The following is a description of a gene set: studied in species Mus musculus Genes negatively differentially expressed in cell type: cDC1 (conventional dendritic cell type 1) upon treatment with cytokine: IL-15 in mouse lymph nodes in vivo. Mouse Gene Set: CUI_CDC1_IL15_RESPONSE_DN from publication Cui A, Huang T, Li S, Ma A, Pérez JL, Sander C, Keskin DB, Wu CJ, Fraenkel E, Hacohen N (PMID 38057668) Cytokines mediate cell-cell communication in the immune system and represent important therapeutic targets. A myriad of studies have highlighted their central role in immune function, yet we lack a global view of the cellular responses of each immune cell type to each cytokine. To address this gap, the authors created the Immune Dictionary, a compendium of single-cell transcriptomic profiles of more than 17 immune cell types in response to each of 86 cytokines (>1,400 cytokine-cell type combinations) in mouse lymph nodes in vivo. A cytokine-centric view of the dictionary revealed that most cytokines induce highly cell-type-specific responses. For example, the inflammatory cytokine interleukin-1β induces distinct gene programmes in almost every cell type. A cell-type-centric view of the dictionary identified more than 66 cytokine-driven cellular polarization states across immune cell types, including previously uncharacterized states such as an interleukin-18-induced polyfunctional natural killer cell state., and this is the list of marker genes: Igbp1, Tubb2a, Fbl, Ighm, Zfp36l2, Pglyrp1, Polr1d, Ckb, BC028528, Rab7b, Celf2, Sec11c, Rsl1d1, Pianp, Ap1b1, H2-Ob, Lat2, Pten, Arhgap45, Hnrnpa1 (NCBI Gene Id 52621), Pdcd2l, Rp9, Rtcb, Eif2b2 (NCBI Gene Id 97826), Septin3, Il6ra (NCBI Gene Id 16194), Ctdp1, Zmiz1, Cd44 (CD44 antigen, NCBI Gene Id 99339), Glul, Atp5mc2, Smc4, Treml4, Hnrnpr, Elovl5, Msl1, Sigmar1, Cxcr3, Plekha5, Cir1, Znrf2, Pid1, St3gal5, Lamtor4, Naca, Git2, Mrpl34, Prdx6, Ndufc2, Septin6, Lage3, Xpr1, Mrpl52, Myl12b, Cebpz, Creg1, Naa10, Tm2d2, Evl, Tsc22d3, Cox7a2l, Mlec, Cyb5a, Mxd4, Bri3bp, Sf3b1, Rgs10, Klhl24, Arhgef6, Rtl8b, Ciao2a, Csk, Sec61b, Camk1d, Tbc1d10c, Glo1, Anp32b, Cdc26, Pold4, Shtn1, Mapk14, Gmfg, Gsn, Ccr2, Abcd1, Uqcc3, Kcnq1ot1, Il16, Kctd12, Hepacam2, Itpripl1 (inositol 1,4,5-triphosphate receptor interacting protein-like 1), Fos, Eef2, Wdr26, Clk1, Rab32, Bnip3l (NCBI Gene Id 97931), Ifngr1, Rnf144b, Gdi2, Zfp706, Acss1, Polr2e, Eif4b, Gpx1, Mfsd14a, Gpi1, Slc66a2, Cd48, Rgs2, Dusp1, Igsf6, Gpsm3, Cbx3, Tbl1xr1, Ppm1m (NCBI Gene Id 97511), Scp2, Nsmaf, Rnd3, Glud1, Siglecg, Eif3h, Niban1, Plekho1, Nap1l1, Uba52, P3h2, Cat, Unc119, Tmsb10, Ptpre, Hnrnpl, Ypel3, Ppt2, Serpinf1, Sgpp1, Arhgdib, Bmyc, Commd8, Ptma (NCBI Gene Id 19231), Hspe1, Akna, Snx21, Sla, Srsf11, Stx17, Usf2, Klf4, Slc35c2, Dipk1a, Ucp2, Ramp1, Sdf2, Itga1, Trf (NCBI Gene Id 22041), Gpr65, Itgb7, Rex1bd, Ptpn18, Cenpv, Myo1f, Syne1, Txndc15, Coro1a, Hells, Otulinl, Tut4, Pdcd4, Tnrc6b, Ppt1, Cd300c2, Supt4a, Srebf2, Cnpy2, Ppp1r14b (protein phosphatase 1, regulatory inhibitor subunit 14B), Lbh, Ivns1abp, Adrb2, Rhob, Aph1c, Arhgap18, Surf1, Selenoh, Lipa, Hmgb1 (NCBI Gene Id 15289), Pdlim2, Jun, Hps3, Nfam1 (Nfat activating molecule with ITAM motif 1), Trim28, Man2b1, Mia2, Rsrp1 (arginine/serine rich protein 1), Colgalt1, Atp5if1, Tm6sf1, Rtl8a, Kctd14, H1f2, Inpp5d, Snx22, Mrps21, Top2b, Arsb, Lrrc25, Mef2c, Ap2a2, Tmco1, Sars1, Pak1, Erp29, Brd3, Npm1, Anp32a, Fosb, Irag2, Ttc39a, Tnfaip8, Klf2, Proser2, Scd2, Asap1, Tsc22d4, Id2, Ubb, Btg2, Rassf5, Ccdc12, Zmynd8, Alox5ap, Mrtfa, Polr1a, Pld4, Mrpl43, Fermt3, C1qbp, Atad2, Tlr12, Rnase6, Tomm5, Rgs18 (regulator of G-protein signaling 18)